Given this list of marker genes Entpd7 (NCBI Gene Id 93685), Entpd4, Entpd6, Entpd4b, Cant1, Entpd1, Entpd5, Entpd2, Entpd8, Entpd3, here is a description of the gene set: Mouse Gene Set: GOMF_UDP_PHOSPHATASE_ACTIVITY Catalysis of the reaction: UDP + H2O = UMP + phosphate. species: Mus musculus